Given this list of marker genes Vangl2, Id2, Nsd2, Tgfbr2, Fgfr2, Fzd1, Bmp4, Tgfb2, Nog, Fzd2, here is a description of the gene set: studied in species Mus musculus The process in which the membranous septum is generated and organized. The membranous septum is the upper part of ventricular septum. Mouse Gene Set: GOBP_MEMBRANOUS_SEPTUM_MORPHOGENESIS